The following is a description of a gene set: Any process that modulates the frequency, rate or extent of smooth muscle cell differentiation. studied in species Homo sapiens Human Gene Set: GOBP_REGULATION_OF_SMOOTH_MUSCLE_CELL_DIFFERENTIATION, and this is the list of marker genes: PRDM6, HEY1 (NCBI Gene Id 23462), SOD2, MECP2, NFATC2, NFATC1, PDGFB, MYOCD, NOTCH4, SIRT1, RBPMS2, TGFB1, PDCD4, EFEMP2, MIR15B, DNMT1, SMARCD3, RCAN1, PIAS1, MIR221, FOXO4, NOTCH1, SHH, MIR22, ENG, MIR140, HEY2, MIR1-1, MIR21, FGF9, MIR100, SRF, MIR26A1, ZEB1, MIR34A, MIR125B1, CTH, EREG, MIR199B, FGFR2, MIR18A, BMP4, MED28, OLFM2, GPER1, NOTCH2, MIR424, MIR145, KIT, NFATC3